The following is a description of a gene set: Mouse Gene Set: RAO_BOUND_BY_SALL4_ISOFORM_A from publication Rao S, Zhen S, Roumiantsev S, McDonald LT, Yuan GC, Orkin SH (PMID 20837710) species: Mus musculus Murine embryonic stem (ES) cells are defined by continuous self-renewal and pluripotency. A diverse repertoire of protein isoforms arising from alternative splicing is expressed in ES cells without defined biological roles. Sall4, a transcription factor essential for pluripotency, exists as two isoforms (Sall4a and Sall4b). Both isoforms can form homodimers and a heterodimer with each other, and each can interact with Nanog. By genomewide location analysis, we determined that Sall4a and Sall4b have overlapping, but not identical binding sites within the ES cell genome. In addition, Sall4b, but not Sall4a, binds preferentially to highly expressed loci in ES cells. Sall4a and Sall4b binding sites are distinguished by both epigenetic marks at target loci and their clustering with binding sites of other pluripotency factors. When ES cells expressing a single isoform of Sall4 are generated, Sall4b alone could maintain the pluripotent state, although it could not completely suppress all differentiation markers. Sall4a and Sall4b collaborate in maintenance of the pluripotent state but play distinct roles. Our work is novel in establishing such isoform-specific differences in ES cells. Loci bound exclusively by SALL4 isoform a in ES cells (embryonic stem)., and this is the list of marker genes: Or6b2b, Slc22a28, Prh1, Serpinb9d, Or9g8, Kat2b, Ddx60, Pou1f1, Smyd4, Fbxl21, Or5h18, Usp54, Mrpl13, Calu, Septin7, Rxrg, Stx19, Vmn2r63, Mlh1, Mapt, Vmn1r40, Xirp2 (xin actin-binding repeat containing 2), Aldh1a2, Or8b1, Klra7, Sacm1l, Cdh8, Cyp2c69, Snap25, H4c2, Ppp3r2, Adam34, Akr1c21, Or10d4c (olfactory receptor family 10 subfamily D member 4C), Cfap53, Rhobtb3, Insm1, Chil3, Pou3f3, Canx, Serpinb3a, Or12d13, Baiap2l1, Or8g23, Or1n2, R3hcc1l, Or6c2b, Arhgap6, Specc1, Psd3, Has2, Ces1b, Kcnj3, Glra3, 4933434E20Rik, Or7g31, Or6c33, Adam25, Hspb3, Gabrb1, Fzd8, Prg4, Or5p50, Vmn1r235, Foxj2, Dus2, Maea, Desi2, Gtf2a2, Or5p51, Gng12, Abca1, Tmprss11b, Dmxl1, Phf10, Ercc5, Or4k15, Pou2f1, Or4k5, Runx1t1, Vmn2r18, Or10g9, Or5m9, Ppp3cb, Stap1, Ank3, Vmn1r29, Trap1, Pitx2, Gm12695, Or4f4b, Or4c107, Jkamp (NCBI Gene Id 70280), Prag1, Snx12, Rbl1, Or5as1, Lrrn1, Ciapin1, Tas2r115, Psen1 (NCBI Gene Id 19164), Vps54, Lix1, Ptgs2, Mthfd1, Carf, Rln1, Vmn2r99, Prrx1, Slc22a29, Echdc1 (NCBI Gene Id 66937), Plpp6, Xpo6, Pkn2, Trip12, Dpy19l3, Fbxl4, Dnajb4, Mmd (monocyte to macrophage differentiation-associated), Serpine2, Cftr, Aldh1a1, Or5p5, Qsox1, Vmn1r234, Stxbp5l, Rgs9, Ugt2a3, Sem1, Or4f15, Serpinb10 (serine (or cysteine) peptidase inhibitor, clade B (ovalbumin), member 10), Olfr908, Sprr2a1, Krtap21-1, Wfdc6b, Reep5, Or8k32, Ric3, Adamts18, Acmsd, Aff4, Hlcs, Adam19, Mobp, Nfat5, Lrig2, Epb42, Fat1, Idh3b (NCBI Gene Id 96966), Setdb2, Pes1, Armc3, 2310057J18Rik, Shroom3, Rnf185 (ring finger protein 185), Ugp2, Nipbl, Or4l15, Zfp607a, Vmn2r111, Rsrc1, Vmn2r66, Lmna, Cdc5l, Or4c12b, Artn, Cxxc4, Asah2, Ly75, Mitf, Cdkn2a, Tnfrsf1b (NCBI Gene Id 21938), Spata6l, Nedd4, Mab21l1, Or52p1, Dync2li1, Vps36, Phkb, Krtap19-1, Polq (NCBI Gene Id 77782), Aplf, Or4d10c, Or9m2, Marchf8, Mff, Ulk1, Mmaa, Rspo3, Or8k35, Cyp2r1, Gab3, Ubr3, Kif27, Vstm2a, Tmed11, Fbxl14, Cckar, Adam10, Mblac1, Or4d10b, Arx, Slc5a7, Cyp2c68 (cytochrome P450, family 2, subfamily c, polypeptide 68), Rfx7, Or5p73, Commd3, Rell1, Vmn1r15, Plcb4, Ctf1, Gcn1, Ppme1, Grip1, Ran, Rbp4, Pcdh11x, Tspan8, Gucd1, Chst4